The following is a description of a gene set: Human Gene Set: REACTOME_SYNTHESIS_OF_PIPS_AT_THE_EARLY_ENDOSOME_MEMBRANE species: Homo sapiens Synthesis of PIPs at the early endosome membrane, and this is the list of marker genes: INPP4B, PIK3C3, FIG4, MTMR10 (myotubularin related protein 10), INPP4A, MTMR12, PI4K2A, MTM1, PI4K2B, MTMR2, PIK3C2A, PIK3R4, INPP5F, PIKFYVE (NCBI Gene Id 387568), VAC14, MTMR4